Given this list of marker genes PANK3, COASY, DCAKD, PANK2 (pantothenate kinase 2), PPCS, PANK1 (pantothenate kinase 1), PPCDC, here is a description of the gene set: Coenzyme A biosynthesis Human Gene Set: REACTOME_COENZYME_A_BIOSYNTHESIS species: Homo sapiens